The following is a description of a gene set: species: Mus musculus Up-regulated genes in the 'Field Effect' signature of normal lung tissue adjacent to the tumor. One area of intensive investigation is to understand complex cellular and signaling interactions in the tumor microenvironment. Using a novel, although straightforward, microarray approach, we defined a gene expression signature from the lung tumor microenvironment in the murine A/J-urethane model of human lung adenocarcinoma. The tumor microenvironment is reflected by the composition of the cell types present and alterations in mRNA levels, resulting in a Field Effect around the tumor. The genes composing the Field Effect expression signature include proteases and their inhibitors, inflammation markers, and immune signaling molecules. By several criteria, the Field Effect expression signature can be attributed to the macrophage lineage, suggesting a qualitative change in the expression pattern of tumor-associated macrophages (TAM) observed in lung tumors. The protein expression levels for a number of Field Effect genes were verified by Western blot analysis of lung homogenates, and for their expression in macrophages and parenchymal cells outside of the tumors by immunohistochemistry. In addition, the Field Effect expression signature was used to classify bronchoalveolar lavage (BAL) cells from tumor-bearing or age-matched control mice. Using a variety of statistical measures, the Field Effect expression signature correctly classified the BAL cells >94% of the time. Finally, the protein levels for several Field Effect genes were higher in cell-free BAL fluid, indicating they may be secreted by the TAMs. This work suggests that TAMs generate a unique gene expression signature within the tumor microenvironment, and this signature could potentially be used for identifying lung cancer from BAL cells and/or fluid. from publication Stearman RS, Dwyer-Nield L, Grady MC, Malkinson AM, Geraci MW (PMID 18172294) Mouse Gene Set: STEARMAN_TUMOR_FIELD_EFFECT_UP, and this is the list of marker genes: Ptgs1, Acp5, Ccn3, Apoc1, F7, Wfdc21, Ctsk, Plet1, Sirpa, Sat1, Spp1, Pld3, Lyz2, Wdr81, Csf2rb2, Cd68, Pira1, Ctsz, Cstb (cystatin B), Mpeg1, Ctsd, Iqgap1, Itih4, Serpina10, Lpl, Scarb2, Ly75, Lrg1, Scd1, Myo7a, Csf2rb, Ctss, Ccl6, Cd200, Clec4a2, Lcn2, Socs3, Chi3l1, Itgax